The following is a description of a gene set: Human Gene Set: REACTOME_PHOSPHORYLATION_OF_CLOCK_ACETYLATION_OF_BMAL1_ARNTL_AT_TARGET_GENE_PROMOTERS Phosphorylation of CLOCK, acetylation of BMAL1 (ARNTL) at target gene promoters studied in species Homo sapiens, and this is the list of marker genes: KMT2A, NR1D1, PER1, CREBBP, RORA, PER3, BMAL1, PER2, CRY1, CRY2, CLOCK (NCBI Gene Id 9575)